The following is a description of a gene set: Mouse Gene Set: GOBP_NON_LYTIC_VIRAL_RELEASE The exit of a viral particle from a host cell that does not involve cell lysis. studied in species Mus musculus, and this is the list of marker genes: Chmp1a, Vps4a, Vps4b, Arl8b, Chmp3, Chmp2b, Chmp4b, Chmp7, Chmp6, Chmp4c, Chmp1b, Chmp2a, Chmp1b2 (NCBI Gene Id 74520), Chmp5